The following is a description of a gene set: Genes down-regulated in peripheral blood monocytes (PMBC): healthy versus mixed infection sepsis. To identify signature genes that help distinguish (1) sepsis from non-infectious causes of systemic inflammatory response syndrome, (2) between Gram-positive and Gram-negative sepsis. studied in species Homo sapiens from publication Payen D, Lukaszewicz AC (PMID 19535937) Human Gene Set: GSE9960_HEALTHY_VS_GRAM_NEG_AND_POS_SEPSIS_PBMC_DN, and this is the list of marker genes: TNKS, SAMD8, EAF1, DCUN1D1, TXNL1, AVL9, KDM2A, KYNU, BET1, ATP11A, STRN3, API5, PLAGL1, EIF2AK3, STARD3NL, TMTC2, CPA3, EPM2AIP1, ZBTB11, ADAM17, CCN2, OSMR, SLC2A6, H3C6 (H3 clustered histone 6), ZKSCAN5, TM2D3, MIER3, KANSL1-AS1, GTF2IP20, ZBED4 (NCBI Gene Id 9889), LYPLA1, PIP4P2, LYRM4, FLVCR1 (NCBI Gene Id 559), EME1, ZNF593, DGKH, HOOK3, SLAIN1, CCNB1, A2M-AS1, KHDC4, SDHAF4, PLEKHA3 (pleckstrin homology domain containing A3), USP46, IRF8, RNF34, IRAK2, PPP3CA, TMEFF1, ADAM21, LRBA, PHAX, ELL2, DYNLT3, ZIK1, GOLIM4, HIPK1, CIBAR1, NUP155, NSD1, PDZD8, CCL8, TIMM23, SCRN3, TMEFF2, C10orf53, ZNF253, MT1G, RABL3, ZBTB41, FPGT, STK17A (serine/threonine kinase 17a), SLC25A43, KLHL15, C1RL, ZNF217, TCEAL1, ZSCAN26, TRAPPC6B, PLPP5, ZBTB17, SNRPN, SLC25A15, ZNF701, TVP23B, HSCB, L3HYPDH, NEDD1, UBQLN2, ATRX, BFSP2-AS1 (NCBI Gene Id 85003), KSR1, ZNF426, KRIT1, EZH2, ZNF302, P4HA1 (prolyl 4-hydroxylase subunit alpha 1), RAD9B, MPHOSPH10, GABPB1, IMMP1L, ZNF582, ASPHD2, CRYBG3, PTGR2, NEURL3, CYCS (cytochrome c, somatic), SH3D19, SNX10, ZNF43 (zinc finger protein 43), TSPAN2, LRRFIP2, CNTRL, GPR84, USP12, LINC02860, VPS13B, DTWD2, CLEC4E, RBMXL1, FAM217B, MIR3142HG, ZNF567, VPS36, KCTD18, GRAMD2B, NHLRC3, ISOC1, PIK3R1, LINC01102, RALGAPA1, PHF3, FCHSD2 (FCH and double SH3 domains 2), MON2, TRUB1, DCP1B, SELENOW, NKAPD1, SCYL2 (NCBI Gene Id 55681), MANEA, PLEKHH1, OR52D1, TNFSF15, KAT2B, SLC30A9, MBTPS2, PSTPIP2, PTTG1, CIMAP2, BDP1, LYRM1, RFFL, SGPP2, THAP6 (THAP domain containing 6), HLA-F-AS1, ZNF451, TUBGCP4, CMAS, PGM2, CXorf65, TMEM64, N4BP1, ZBTB43, MIDEAS, SRD5A1, MBTD1, ZMYM6, TTF1, NAA16, CAAP1, C8orf76, HYCC2, ATAD2B, SLC35A5, CD58, IRAK4, STT3B, NDUFB5, WTAP, UTS2, PHOSPHO2, SBNO1, DNAJC28, SMC5, OGFOD2, ERBIN, NFKBIE, DIDO1, KCNRG, YME1L1, ZNF189, PITPNA-AS1, OR11A1, FBXO21, CSTPP1